The following is a description of a gene set: Human Gene Set: HP_ABNORMAL_RESPONSE_TO_ACTH_STIMULATION_TEST studied in species Homo sapiens An anomalous response to stimulation by administration of the adrenocorticotropic hormone (ACTH). ACTH stimulation normally stimulates the adrenal glands to release cortisol and adrenaline. Abnormal response to ACTH stimulation test, and this is the list of marker genes: POR, RBM28, MC2R, CYP17A1, NFKB2, TXNRD2